Given this list of marker genes IPO9, UCK2, SRSF3, TMEM70, JRK, MCM3, CCT3, CD8B, TGIF2, LUC7L3, CENPF, CSPP1, SRSF1, H4C3 (H4 clustered histone 3), SRRT, ANP32A, here is a description of the gene set: Propensity for subsequent distant metastasis in head and neck squamous-cell carcinoma (HNSCC) was analysed using 186 primary tumours from patients initially treated by surgery that developed (M) or did not develop (NM) metastases as the first recurrent event. Transcriptome (Affymetrix HGU133_Plus2, QRT-PCR) and array-comparative genomic hybridization data were collected. Non-supervised hierarchical clustering based on Affymetrix data distinguished tumours differing in pathological differentiation, and identified associated functional changes. Propensity for metastasis was not associated with these subgroups. Using QRT-PCR data we identified a four-gene model (PSMD10, HSD17B12, FLOT2 and KRT17) that predicts M/NM status with 77% success in a separate 79-sample validation group of HNSCC samples. This prediction is independent of clinical criteria (age, lymph node status, stage, differentiation and localization). The most significantly altered transcripts in M versus NM were significantly associated to metastasis-related functions, including adhesion, mobility and cell survival. Several genomic modifications were significantly associated with M/NM status (most notably gains at 4q11-22 and Xq12-28; losses at 11q14-24 and 17q11 losses) and partly linked to transcription modifications. This work yields a basis for the development of prognostic molecular signatures, markers and therapeutic targets for HNSCC metastasis. Down-regulated genes that vary between HNSCC (head and neck squamous cell carcinoma) groups formed on the basis of their level of pathological differentiation: moderately vs poorly differentiated tumors. from publication Rickman DS, Millon R, De Reynies A, Thomas E, Wasylyk C, Muller D, Abecassis J, Wasylyk B (PMID 18679425) studied in species Homo sapiens Human Gene Set: RICKMAN_TUMOR_DIFFERENTIATED_MODERATELY_VS_POORLY_DN